Given this list of marker genes Tgfb1, Pus10, Mettl3, Ncbp2, Srrt, Stat3, Ddx5 (NCBI Gene Id 72118), Hnrnpa2b1, Srsf3, Mecp2, Dgcr8, Ddx3x, Ncbp1, Drosha, Il6, Bmp4, Lin28b, here is a description of the gene set: species: Mus musculus Mouse Gene Set: GOBP_PRIMARY_MIRNA_PROCESSING A process involved in the conversion of a primary microRNA transcript into a pre-microRNA molecule.